Given this list of marker genes CYP26C1, here is a description of the gene set: part of: Metabolic disorders of biological oxidation enzymes species: Homo sapiens Retinoic acid (RA) is a biologically active analogue of vitamin A (retinol). RA plays an important role in regulating cell growth and differentiation. CYP26C1 is involved in the metabolic breakdown of RA by 4-hydroxylation. While CYP26C1 can hydroxylate the trans form, it is unique in hydroxylating the 9-cis isomer of RA (9cRA). Defects in CYP26C1 can cause focal facial dermal dysplasia 4 (FFDD4; MIM:614974), a rare syndrome characterised by facial lesions. Reactome Pathway: Defective CYP26C1 causes FFDD4